Given this list of marker genes ARID1A, SSBP3, TFAP2D, ZNF362, LIF, STAG2, CHD2 (NCBI Gene Id 283680), MIGA2, RCL1, KAT5, CCER1, AP1B1, HOXD9, TRERF1, TSEN54, LIN28A, NRGN, PRKCI, AJUBA, POU4F3, PHF12, FOS, DHX30 (DExH-box helicase 30), GREM1, SLITRK5, STC1, YWHAG, HOXC5, ATF7, PPIE, BCAM, NCAM1, DLX3, EFNB3, CALM1, MECOM, ATXN7L2, TSC22D3, GRM3, RARG, TPT1, CTCF, PTK7, TMEM30A, LLCFC1, KCNIP2, ATOSB, TGFB3, NEUROD2, PRIMA1, AAMP, HES7, ZNF513, MPC2, CYP24A1, BHLHE40, TBR1, PPM1J, NUFIP2, PHF20 (NCBI Gene Id 80330), FBRS (fibrosin), GGA1, PICALM, NHLH1, GPR173, POU2F1 (NCBI Gene Id 7823), SOX15, FSCN3, HOXA3, EIF4G2, EIF5A (NCBI Gene Id 1984), KCND1, FGFR2, LMO4, LAG3, MAZ, KLK13, ORAI1, ZNF688, HNRNPUL1, CCT7, INHA, PTCH1, RFX5, GRK5, GDF1, TMEM187, PTPN22, SATB1, NDUFA6, HRK, NCOA6, HOXA2, VEGFA, EMSY, PRADC1, NR4A3, PAX8, GTF2A1, DUOX2, PRRT2, RARB, ARHGEF15, CHRM1, TMEM39A, TIMP3, PRKCH, ASXL1, CXXC4, HOXB8, RALGPS2, DUOXA2, NR2F1, ZBTB7A, POGK, TRPS1, MORF4L1, POM121L1P, KLHL41, PAGR1, PATL1, THRA, ENSA, VEZF1, TAOK2, BCL11B, DHH, CXCL14, GRID2, BMF, SOX10, METRN, JUND, FBXL19, MED26, ARHGEF2, PTMS, MEIS2, EIF4E, POGZ, AKT2, LRP1, TCF15, HIF3A, SMARCA5, GPR4, WNT11, SRF, NLK, ZNF436-AS1, MMP14, NTRK3, FLI1, ARHGAP8, HOXB7, KCNB1, AGAP2, RBM26, DACT3, DCHS1, ADRB1, ADRA2C, HTN1, ZNF385A, PLXNB3, NXPE3, CHMP2B, SLC26A10P, MSI1, PRKAG1, HAS1, RRBP1, ZBTB18, PLCB3, NUMBL, CD5L, RBBP6, SIN3A, SKIDA1, TLCD3B, ADGRL1, ERRFI1, PRX, CLDN15, TBX2, CASKIN2, SEC63 (SEC63 homolog, protein translocation regulator), TGFB1 (transforming growth factor beta 1), TLE3, BHLHE41, ZNF436, ZBTB9, SLC2A4, EGLN2, CERS1, SHOX2, FBXL19-AS1, BAHD1, GPBP1L1, XPO7, SLC12A5, FURIN, SH3KBP1 (NCBI Gene Id 94010), ADGRG3, XPO1, NTRK1, FKBP2, GSK3B, PNKD, PCBP2, JAKMIP3, PAN2, FOXB1, LCOR, IL11, NLGN3, TXNDC12, FOXJ2, RAB6B, LMO1, FGF9, PROX1, ATP1A2, R3HDM2 (NCBI Gene Id 51220), POLG, PBX1 (PBX homeobox 1), SHFL, EBF1, KRT13, PCDH7, PLXDC2, FBXO36, here is a description of the gene set: Human Gene Set: VDR_Q3 Genes having at least one occurrence of the motif GGGKNARNRRGGWSA in the regions spanning 4 kb centered on their transcription starting sites. This matches the VDR transcription factor binding site V$VDR_Q3 (v7.4 TRANSFAC). studied in species Homo sapiens